Given this list of marker genes POP7, NTHL1, EXOSC3, MBD4, RPP38, PRORP, RNASE11, MAP1S, PDE12, MUS81, ANKZF1, PIWIL3, ENDOV, TRIR, DNASE1L2, RCL1, PMS2, DIS3, TSEN34, BRAT1, FANCM, XRN2, KHNYN, PLD6, RNASE2, REXO1L1P, SLX1B, EXOSC9, AGO2, POLD1, MBLAC1, APEX1, ZC3H12C, DNASE1, DIS3L, DFFB, DCPS, RNASET2, EXOSC8, NME8, N4BP1, TSEN2, DNASE2B, EXOSC7, ERI2, NME5, RPP30, EXOSC6, ENDOD1, RAD1, USB1, ELAC1, AGO1, ANKLE1, BIVM, YBEY, DXO, XRN1, PPP1R8, CNOT8, PIWIL2, REXO4 (NCBI Gene Id 90950), DYNLL1 (NCBI Gene Id 8655), TREX2, SLFN11, SAMHD1, SND1, RPP21, CWF19L1, EXOSC10 (NCBI Gene Id 8619), DDX1, POLE, ENPP3, REXO5, PLD3, XRCC3, MEIOB, OGG1, RIDA, NME1, EXOSC1, ELAC2, ZRANB3, RNASE3, PARN, RNASE6, RNASE9, RNASE4, XRCC1, NME7, DNASE2, TSNAX, NOB1, PGBD5, RPP40, CNOT6, AEN, DCLRE1A, ERN1, TREX1, RAG1, RAD50, ERI1, RNASE1, REXO1, AGO3, TSN, RNASEK, RNASE13, EXOSC2, ERI3, TOE1, TATDN3, ENDOU, CNOT7, AZGP1, POP5, N4BP2, SLX1A (NCBI Gene Id 548593), CNOT1, PNKP, NUDT16, DNASE1L1, PAN2, NUDT16L1, APEX2, EXOSC4, SMG6, LAS1L, ZC3H12A, DBR1, WRN, RNASEH1, FEN1, PXDNL, NYNRIN, PAN3, CNOT2, DICER1, NOCT, RNASEL, RNASEH2A, RPP14, RAD9A, RNASE7, ABCE1, ENDOG, ZC3H12B (NCBI Gene Id 340554), C1QBP, PNLDC1, G3BP1, SLFN13, SETMAR, MARF1, DIS3L2, ENPP1, RPS3, POLG, EXO5, RPPH1, TATDN2, CNOT6L, RNASE12, LACTB2, PLD4, ZC3H12D, DCLRE1C, ISG20, DNASE1L3, DFFA, EXD2, ERCC1, MYG1, MRPL44, TATDN1, APLF (NCBI Gene Id 200558), EXOG, UBE3D, MRE11 (MRE11 homolog, double strand break repair nuclease), EME2, RAD51C (NCBI Gene Id 5889), RNASE8, ANG, PIWIL1, TMBIM6, TEFM, DCLRE1B, EXOSC5, SLFN12, ERCC4, PLSCR1, AGO4, NUDT12, SLFN14, TDP2, TDP1, POP1, ISG20L2, RNASE10, EME1, DNA2, EXO1, ENPP2, HELZ2, HARBI1, ERCC5, RBBP8, ASTE1, APTX, RNH1, FAN1, CPSF3, RPP25, PIWIL4, POLRMT, GEN1, MGME1, EXD1, DCP2 (decapping mRNA 2), ERN2, PNPT1, INTS11, POP4, EXD3, REXO2, DROSHA, here is a description of the gene set: Human Gene Set: GOMF_NUCLEASE_ACTIVITY studied in species Homo sapiens Catalysis of the hydrolysis of ester linkages within nucleic acids.